The following is a description of a gene set: studied in species Homo sapiens Human Gene Set: HP_INTESTINAL_FISTULA Intestinal fistula An abnormal connection between the gut and another hollow organ, such as the bladder, urethra, vagina, or other regions of the gastrointestinal tract., and this is the list of marker genes: RNU12, IL10RB, POLR1D, PIGN, POLR1B, CD3G, MKKS, POLR1C, NCF4, TCTN3, PKP1, PI4KA (phosphatidylinositol 4-kinase alpha), RECQL4, LONP1, SYK, CDK8, KDM6A, SALL1, DOCK2, TGFB1, SPINT2, CCNQ, KMT2D, FREM1, B3GLCT, UBR1, DDB1, ELF4 (E74 like ETS transcription factor 4), KIF7, MNX1, SALL4, JAK3, TCOF1, DACT1, MID1